Given this list of marker genes KRAS, GLI1, OSTN, ZFPM2, MIR195, CCNB1, TGFBR2, PAK1, ACVR2B, WT1, FLVCR1, TSKU, DDR2, MSX2, MIR23A, MIR208A, STC1, BMP10, FXN, RSPO2, MESP1, PROX1, MIR24-1 (microRNA 24-1), PRLR, TGFB2, MIR204, WWC3, RBPJ, RAG2, BASP1, AKT1, COL27A1, MAPK11, CTDP1, NLGN4X, SPRY2, SERP1, MIR19A, ABL1, PLAG1, NPPA, HEY2, PTEN, SHH, NOG, TGFBR1, RGS4, EDN1, NKX2-5, TMEM38B, LATS1, YY1, SOX9, POC1A, FGF9, CGA, FGFR3, FOSL2, MAEL, FGF10, BCL2, MYH6, FOXC2, ZMPSTE24, SLC6A4, DIPK2A, SMO, MEF2C, CLDN18, PI16, YBX3, TP73, THBS3, ADPRHL1 (ADP-ribosylhydrolase like 1), RARB, LEPR, FBLN5, MMP13, MIR199A1, PIM1, AKAP6, TOMM70, WWC1, NPPC, BCL2L11, RARG, HEG1, ESR1, ERBB4, ARX, SASH3 (SAM and SH3 domain containing 3), MIR222, UBE3A, STK4, ACACB, PRKAR1A, SKI (SKI proto-oncogene), IL7, FOXC1, YAP1, AR, NOTCH1, GJE1, EXT1, MIR590, JARID2, STK3, SOD1, RGS2 (regulator of G protein signaling 2), MIR19B1, IGF1, RBP4, CDK1, NPR2, S1PR1, TGFBR3, EHMT2, CACNA2D2 (NCBI Gene Id 9254), SORBS2, G6PD, FES, NDRG4, RUNX1, KCNK2, BNC2, PPARA, WWC2, LEP, SMAD2, MYH10, SAV1, EVC, DUSP6 (NCBI Gene Id 1848), FGF7, MIR25, ATF2, FOXP1, FGF2, CAV3, GATA4, TBX20, FGF20, FGFR2, IGF2, FGF8, GSK3A, IER3IP1, SMPD3, FGFR1, TBX5, MIR873, CER1, CYP19A1, COL14A1, PTPN11, POR, GATA6 (NCBI Gene Id 2627), MIR199B, MIR200B, ECM1, SMAD1, HLX, NRG1, PARP2, PDLIM5, MEIS1, MIR17HG (NCBI Gene Id 407975), MATN1, MIR509-1, RXRB, IFT80, RARA (NCBI Gene Id 5914), PRKG1, MAPK14, DLL1, MIR1-1, ARID2, VGLL4, COMP, PSAPL1 (NCBI Gene Id 768239), MIR548C, TBX2, TENM4, WNT2, LATS2, PSAP, ADRA1A, BMPR1A, here is a description of the gene set: The increase in size or mass of an organ. Organs are commonly observed as visibly distinct structures, but may also exist as loosely associated clusters of cells that function together as to perform a specific function. Human Gene Set: GOBP_ORGAN_GROWTH species: Homo sapiens